The following is a description of a gene set: Human Gene Set: GOBP_NEGATIVE_REGULATION_OF_CELL_ADHESION_MOLECULE_PRODUCTION species: Homo sapiens Any process that decreases the rate, frequency or extent of cell adhesion molecule production. Cell adhesion molecule production is the appearance of a cell adhesion molecule as a result of its biosynthesis or a decrease in its catabolism., and this is the list of marker genes: MIR222 (NCBI Gene Id 407007), MIR374A, MYOCD, MIR20A (NCBI Gene Id 406982), MIR101-1, MIR221, NOTCH1, CXCL8, MIR27B, APOA1, MIR146A, NOTCH4 (NCBI Gene Id 4855), MIR206, MIR1298